Given this list of marker genes IHH, PQBP1, NONO, CHSY1, FGFR2, SF3B4, RAB23, BMPR1B, ERI1, UBAP2L, here is a description of the gene set: Human Gene Set: HP_ABNORMALITY_OF_THE_PROXIMAL_PHALANX_OF_THE_THUMB Abnormality of the proximal phalanx of the thumb species: Homo sapiens An anomaly of the shape or form of the proximal phalanx of the thumb.